The following is a description of a gene set: species: Homo sapiens Human Gene Set: WP_TCELL_RECEPTOR_SIGNALING T-cell receptor signaling, and this is the list of marker genes: IKBKG, NFATC2, PAK1, ITK (NCBI Gene Id 3702), ITPR1, CD4, IL6, SKAP1, PTPN11, MAP3K8, GAB2, MAPK1, FYN, FYB1, GATA3, NFATC1, RIPK2, PSTPIP1, MAPK8, GRB2, HRAS, FAS, WAS, IL17A, IL1A, NFKB1, CD83, CCR5, DBNL, MAPK14, PIK3R2, MAP3K7, TGFB1, RELA, CD3G, MAPK3 (mitogen-activated protein kinase 3), ICOS, VIM, ZAP70, MALT1, CBLB, JUN, MAP2K2, GRAP2, PTK2B, CRKL, CD3E, PLCG1, ATF2, TRAF6, CREB1, IKBKB, CDC42, VAV3, IRF4, MAP4K1, SOS1, IL1B, CBL, IL15RA, NCK1, NFKBIA, OPRM1, SH2B3, LCP2, PRKCQ, AKT1 (AKT serine/threonine kinase 1), CD8A, CD3D, CD247, MAP3K14, PDPK1 (NCBI Gene Id 5170), MAPK9, LCK, CARD11, CRK, PIK3R1, REL (REL proto-oncogene, NF-kB subunit), MAP2K1, PRKCD, SHC1, FOS, RAF1, BCL10, LAT, CHUK, IL9, VAV1 (vav guanine nucleotide exchange factor 1), TNFRSF9, CD28 (NCBI Gene Id 940)